Given this list of marker genes ATP1A2, DSC2, EHD3, DSG2, DMPK, GSTM2, HSP90AA1, RANGRF, JPH1, GJA5, BIN1, RNF207, MIR30E, MYBPC3, CTNNA3, SLC8A3, MYBPH, SUMO1, TNNI3K, C12orf57, ANK2, DLG1, NKX2-5, UCN, REM1, SLC9A1, ASPH, PDE4D, STRIT1, SRI, PLN, STC1, MYL2, PDE4B, ADRA1B, GATA4, ATP2A2, JPH3, KCNQ1, MIR200C, PIK3CG, SCN4A, TRPM4, BMP10, ADORA1, ATP2A1, TNNI3 (troponin I3, cardiac type), FKBP1B, ADGRD1, PKP2, JUP, CASQ2, RYR2, CACNA1C, SCN10A, TRPV4, ADRA1A, P2RX4, ACE2, SCN5A, DSP, JPH4, FKBP1A, PRKD1, MYH7, NOS1 (NCBI Gene Id 4842), MIR133A1, JPH2, ATP1B1, MIR1-1, GRK2, CLIC2, RGS2, ADCY10, CASQ1, KBTBD13, TMEM38A (transmembrane protein 38A), ZC3H12A, GSTO1, CHGA, TNNT3, FGF13, TRDN, TNNI1, CALM1, MYH7B, ACTN3, KCNJ2 (NCBI Gene Id 3759), NPPA, CAV1, CAMK2D, CALM3, HRC, MIR448, SLC8A1, HCN4 (hyperpolarization activated cyclic nucleotide gated potassium channel 4), ATP1A1, DMD, TMEM38B, CALM2, MYL3, SMAD7, AKAP9, CAV3, PRKACA, here is a description of the gene set: Human Gene Set: GOBP_REGULATION_OF_STRIATED_MUSCLE_CONTRACTION species: Homo sapiens Any process that modulates the frequency, rate or extent of striated muscle contraction.